The following is a description of a gene set: species: Homo sapiens Human Gene Set: GOBP_STRIATED_MUSCLE_ATROPHY A process, occurring in striated muscle, that is characterized by a decrease in protein content, fiber diameter, force production and fatigue resistance in response to different conditions such as starvation, aging and disuse., and this is the list of marker genes: ASB2, MYOG, ACTN3 (NCBI Gene Id 89), TRIM63, CFLAR, GSN, MSTN